Given this list of marker genes DISP1, FOXH1, ESCO2, FGF8, NODAL, CDON, ALX3 (ALX homeobox 3), CRIPTO, PTCH1, TGIF1, GLI2, GAS1, SIX3, ZIC2, VSX1, DLL1, STIL, SHH, here is a description of the gene set: Human Gene Set: HP_ANTERIOR_ENCEPHALOCELE studied in species Homo sapiens A type of congenital malformation in which brain tissue protrudes through a defect in the anterior (front) part of the skull. Anterior encephalocele